The following is a description of a gene set: Pregnane X receptor pathway Human Gene Set: WP_PREGNANE_X_RECEPTOR_PATHWAY species: Homo sapiens, and this is the list of marker genes: ABCC4, FOXO1, UGT1A6, UGT1A9, ABCB1, CYP3A5 (cytochrome P450 family 3 subfamily A member 5), NCOA3, CYP2A6, RXRA, NCOA2 (NCBI Gene Id 10499), PSMC5, CYP2C9, ABCC2, SULT2A1, NCOA1, NR1I2, SLCO1B1, HSP90AA1, UGT1A1, UGT1A4, CYP2C19, GSTA2, CYP4F12, PPARGC1A, SRC, DNAJC7, CYP2B6, CYP3A4, SRPX2, NRIP1, ABCC3, CYP3A7